The following is a description of a gene set: The series of events in which a light stimulus is received by a cell and converted into a molecular signal as part of the sensory perception of light. Human Gene Set: GOBP_DETECTION_OF_LIGHT_STIMULUS_INVOLVED_IN_SENSORY_PERCEPTION species: Homo sapiens, and this is the list of marker genes: GRM6, CEP250, GNAT3, EYS, RGS9BP, CACNB4, BEST1, RPE65, CACNA1F, RBP4, GUCY2F, ATP8A2, CACNA2D4 (NCBI Gene Id 93589), CNGB1, ROM1, GNAT2, CRB1, REEP6, TULP1, GNAT1, CCDC66, PRPH2, SEMA5B, GJA10